The following is a description of a gene set: Marker genes curated from the annotated cluster as represented in the Descartes Human Gene Expression During Development database. Human Gene Set: DESCARTES_FETAL_STOMACH_LYMPHATIC_ENDOTHELIAL_CELLS The gene expression program underlying the specification of human cell types is of fundamental interest. The study authors generated human cell atlases of gene expression and chromatin accessibility in fetal tissues. For gene expression, the study authors applied three-level combinatorial indexing to >110 samples representing 15 organs, ultimately profiling ~4 million single cells. The study authors leveraged the literature and other atlases to identify and annotate hundreds of cell types and subtypes, both within and across tissues. Our analyses focused on organ-specific specializations of broadly distributed cell types (such as blood, endothelial, and epithelial), sites of fetal erythropoiesis (which notably included the adrenal gland), and integration with mouse developmental atlases (such as conserved specification of blood cells). These data represent a rich resource for the exploration of in vivo human gene expression in diverse tissues and cell types. species: Homo sapiens from publication Cao J, O'Day DR, Pliner HA, Kingsley PD, Deng M, Daza RM, Zager MA, Aldinger KA, Blecher-Gonen R, Zhang F, Spielmann M, Palis J, Doherty D, Steemers FJ, Glass IA, Trapnell C, Shendure J (PMID 33184181), and this is the list of marker genes: LINC02147, AKR1C2, RADIL, PARD6G, RASSF9, ENSG00000255240, NFATC1, SLC41A1, TNFAIP8L3, EFCC1 (NCBI Gene Id 79825), RTN4RL1, MYZAP, TFPI, CTSL, PTGS2, CCL21, KLHL4, ENSG00000223786, STAB2, MMRN1, TMEM140, SULF2, LY86-AS1, NTS